The following is a description of a gene set: 3-Aminobenzamide (3AB) is an inhibitor of poly (ADP-ribose) polymerase (PARP), an enzyme implicated in the maintenance of genomic integrity, which is activated in response to radiation-induced DNA strand breaks. cDNA macroarray membranes containing 1536 clones were used to characterize the gene expression profiles displayed by mouse BALB/3T3 fibroblasts (A31 cell line) in response to ionizing irradiation alone or in combination with 3AB. A31 cells in exponential growth were pre-treated with 3AB 4mM 1h before gamma-irradiation (4Gy), remaining in culture during 6h until harvesting time. A31 cells treated with 3AB alone presented a down-regulation in genes involved in protein processing and cell cycle control, while an up-regulation of genes involved in apoptosis and related to DNA/RNA synthesis and repair was verified. A31 cells irradiated with 4Gy displayed genes differentially expressed, being detected a down-regulation of genes involved in protein processing and apoptosis, and genes controlling the cell cycle. Concomitantly, another set of genes for protein processing and related to DNA/RNA synthesis and repair were found to be up-regulated. A positive or negative interaction effect between 3AB and radiation was verified for 29 known genes. While the combined treatment induced a synergistic effect on the expression of LCK proto-oncogene and several genes related to protein synthesis/processing, a negative interaction effect was found for the expression of genes related to cytoskeleton and extracellular matrix assembly (SATB1 and Anexin III), cell cycle control (tyrosine kinase), and genes participating in DNA/RNA synthesis and repair (RNA helicase, FLAP endonuclease-1, DNA-3 glycosylase methyladenine, splicing factor SC35 and Soh1). The present data open the possibility to investigate the direct participation of specific genes, or gene products acting in concert in the mechanism underlying the cell response to radiation-induced DNA damage under the influence of PARP inhibitor. Down-regulated synergystically by gamma-irradiation and 3-aminobenzamine, an inhibitor of PARP1. from publication Cardoso RS, Espanhol AR, Passos GA, Sakamoto-Hojo ET (PMID 12379459) studied in species Mus musculus Mouse Gene Set: CARDOSO_RESPONSE_TO_GAMMA_RADIATION_AND_3AB, and this is the list of marker genes: Dpagt1, Mpg, Twf2, Med31, Fen1, Anxa3, Ddx3y, Arhgap17, Dennd4c, Csnk1a1, Alyref, Gstt2, Colq, Bnip2